The following is a description of a gene set: from publication Seki E, De Minicis S, Osterreicher CH, Kluwe J, Osawa Y, Brenner DA, Schwabe RF (PMID 17952090) Hepatic injury is associated with a defective intestinal barrier and increased hepatic exposure to bacterial products. Here we report that the intestinal bacterial microflora and a functional Toll-like receptor 4 (TLR4), but not TLR2, are required for hepatic fibrogenesis. Using Tlr4-chimeric mice and in vivo lipopolysaccharide (LPS) challenge, we demonstrate that quiescent hepatic stellate cells (HSCs), the main precursors for myofibroblasts in the liver, are the predominant target through which TLR4 ligands promote fibrogenesis. In quiescent HSCs, TLR4 activation not only upregulates chemokine secretion and induces chemotaxis of Kupffer cells, but also downregulates the transforming growth factor (TGF)-beta pseudoreceptor Bambi to sensitize HSCs to TGF-beta-induced signals and allow for unrestricted activation by Kupffer cells. LPS-induced Bambi downregulation and sensitization to TGF-beta is mediated by a MyD88-NF-kappaB-dependent pathway. Accordingly, Myd88-deficient mice have decreased hepatic fibrosis. Thus, modulation of TGF-beta signaling by a TLR4-MyD88-NF-kappaB axis provides a novel link between proinflammatory and profibrogenic signals. Mouse Gene Set: SEKI_INFLAMMATORY_RESPONSE_LPS_DN studied in species Mus musculus Genes down-regulated in hepatic stellar cells after stimulation with bacterial lipopolysacharide (LPS)., and this is the list of marker genes: Gstt1, Slc16a9, G0s2, Lyz2, Bmf, Bambi, C1qtnf2, Plekha6, Wnt4, Mmp11, Dbp, Sucnr1, Septin4, Tmem178, Coro2b, Rab3d (NCBI Gene Id 83761), Atoh8, Ablim1, Pdlim2, Synpo, Palm, Gdf10, Selenbp1